The following is a description of a gene set: from publication Chen Y, Wang X (PMID 31504780) Mouse Gene Set: MIR_1298_3P studied in species Mus musculus Genes predicted to be targets of miRBase v22 microRNA mmu_miR_1298_3p in miRDB v6.0 with MirTarget v4 prediction scores > 80 (high confidence targets)., and this is the list of marker genes: Cacnb2, Mpv17l (Mpv17 transgene, kidney disease mutant-like), Trem5, Onecut2, Pias1, Cxcl12 (NCBI Gene Id 20315), Sash1 (SAM and SH3 domain containing 1), Hlf, Ano5, Tmem186, Trpm7, Kirrel3, Appbp2, Mcoln2, Ica1l (NCBI Gene Id 70375), Cnga3, Utp14b, Zfp872, Arhgap32, Mef2d, Zfp788, Cdyl2, Tmed5, Krt5, Marcks, Polr2l, Foxi1, Sema3c, Sh3gl2, Ypel1, Gpr82, Gabra1, Trem4, Rtl4, Mprip, S1pr2, Faxc, Mecp2 (NCBI Gene Id 338503), Fancm, Dock5, Cd83